The following is a description of a gene set: Mouse Gene Set: GOBP_MEIOSIS_I_CELL_CYCLE_PROCESS A process that contributes to the first meiotic division. The first meiotic division is the reductive division resulting in the separation of homologous chromosome pairs. species: Mus musculus, and this is the list of marker genes: Rnf212, Ago4, Psmd13, 1700028K03Rik, Sirt7, Ing2, Tdrd9, Zscan21, Rec114, Spdya, Dmrt1, Sycp1, Msh5, Cdc20, Piwil2, Trip13, Knl1, Tex19.1, Ubr2, Plk1, Rnf212b, Aurka, Pnma5, Dmrtc2, Gsk3b, Cep63, Chtf18, Eif4g3, Trim75, Rec8, Brca2, Top6bl, Topbp1, Birc5 (NCBI Gene Id 11799), Ddx4, Sycp3, Msh4, Terb2, Fancd2, Stag3, Spata22, Mei4, Ehmt2 (NCBI Gene Id 52041), Bag6, Ccne1, Tex12, Fancm, Zcwpw1, Dnmt3l, Terf1, Mre11a, Cenpe, Tex15, Spo11, Meioc, Foxj2, Hspa2, Mybl1, Cdc25b, Prdm9, Brip1, Cntd1, Syce1l, Kash5, Ccnb1ip1, Btbd18, Mov10l1, Syce2, Ube2b, Rad54b, Rad51c, Rad51ap1, Rad54l, Ubb, Pkmyt1, Fmn2, Syde1, Syce1, Hormad1, Cenps, Fbxo5, Ankrd31, Atm, Top2b, Ndc80, Sun1, Psmc3ip, Bcl2l11, Tex11, Mnd1, Ccne2, Mapk15, Eme1, Rad21l, Slx4 (SLX4 structure-specific endonuclease subunit homolog (S. cerevisiae)), Wee2, Zwint, Usp17le, Ercc4, Mlh3, Bend2, Rad51d, Dmc1, Eme2 (NCBI Gene Id 72639), Cdc25c, Top2a, Cks2, Rpl10l, Majin, Syce3, Ankle1, Mael, Pdik1l, Ccnb2, Stk35, Psma8, Morc2b, Ndc1, Espl1, Foxj3, Cenpc1, Cdc25a, Terb1, Rmi1, Siah1a, Iho1, Cenpx, Hfm1, Cpeb1, Brme1, Pttg1, Brdt, Mus81, Hsf2bp, M1ap, Mei1, Mlh1, Slc25a31, Haspin, Meikin, Mcmdc2, 4930447C04Rik, Meiob, Rad51, Shoc1, BC005624